Given this list of marker genes HEPH, AUTS2, DUSP4, CTPS1, BCL11A, DYRK4, PAPOLB, CTNNA3, TBL1XR1 (TBL1X/Y related 1), ARFGAP3, SMCP, ZCCHC17, POLR2M, ATP5F1C, TRDN, GJB2, ABCG1, SLAMF7, SOX9, RNF6, UBL3, MITF, PIAS2, ABCB5, TYW1 (tRNA-yW synthesizing protein 1 homolog), PRPSAP1, TIPARP, SELENOT, MTDH, TENM4, RAB21, CDH13, INPP5A, MYEF2, DDHD2, GCOM1, NAA15, PUS7, LRRC4, DPY19L3, TTC39A, FAM219B, KLF11, TMEM182, LILRA2, ACSL3, CA3, MBNL1, XYLT1, CNR1, JPH1, COL24A1, LPA, GPD2, here is a description of the gene set: Genes predicted to be targets of miRBase v22 microRNA hsa-miR-626 in miRDB v6.0 with MirTarget v4 prediction scores > 80 (high confidence targets). from publication Chen Y, Wang X (PMID 31504780) studied in species Homo sapiens Human Gene Set: MIR626